The following is a description of a gene set: Mouse Gene Set: GOBP_SERINE_TRANSPORT studied in species Mus musculus The directed movement of L-serine, 2-amino-3-hydroxypropanoic acid, into, out of or within a cell, or between cells, by means of some agent such as a transporter or pore., and this is the list of marker genes: Nfkbie, Slc7a10, Sfxn2, Slc38a2, Sfxn1, Slc1a5, Sfxn3, Slc38a5 (solute carrier family 38, member 5), Slc1a4